Given this list of marker genes Abi1, Meox2, Mthfd1, Msgn1 (NCBI Gene Id 56184), Six4, Sfrp1, Aldh1a2, Foxf1, Dll1, Lef1, Wnt1, Nckap1, Sema3c, Med12, Loxl3, Prkdc, Myf6, Lrp6, Notch1, Wdr19, Nup133, Cobl, Smad3 (NCBI Gene Id 17127), Tcap, Kat2a, Lhx1, Six1, Ifitm1, Dll3, Tbx6, Wnt4, Mib1, Tcf15, Dkk1, Bmpr1a, Foxa2, Sfrp2, Ttn, Cdx2, Rad51b, Axin2, Foxc1, Poglut1, Ror2, Smo, Atm, Pofut1, Wnt11 (NCBI Gene Id 22411), Scx, Nog, Ep300, Wnt5a, Foxc2, Frzb, Dmrt2 (doublesex and mab-3 related transcription factor 2), T, Mesp2, Rbbp6, Shh, Pax3, Trp53, Ptch1, Psen1, Gdf3, Ppp2r3a, Rbpj, Taf10, Epb41l5, Nrarp, Nkx3-1, Psen2, Myf5, Nle1, Tbx18, Hes7, Cdx1, Plxna2, Meox1, Wnt3a, Lfng, Pcdh8, Xrcc2, Foxb1, Pax1, Crb2, Palb2, Kdm6a, Smad4, Tmed2, Ihh, Zeb2, Mesp1, Otx2, Ripply2, Ripply1, here is a description of the gene set: The progression of a somite from its initial formation to the mature structure. Somites are mesodermal clusters that are arranged segmentally along the anterior posterior axis of an embryo. studied in species Mus musculus Mouse Gene Set: GOBP_SOMITE_DEVELOPMENT